Given this list of marker genes PDE6D, INPP5E, ARL13B, here is a description of the gene set: part of: Cargo trafficking to the periciliary membrane Reactome Pathway: ARL13B-mediated ciliary trafficking of INPP5E species: Homo sapiens ARL13B is a ciliary-localized small GTPase with an atypical C-terminus containing a coiled coil domain and a proline rich domain (PRD). Mutations in ARL13B are associated with the development of the ciliopathy Joubert's Syndrome. Studies in C. elegans and vertebrates suggest that ARL13B may play a role in stabilizing the interaction between the IFT A and B complexes and the kinesin-2 motors during anterograde traffic in the cilium. Recent work has shown an additional role for ARL13B in trafficking the inositol polyphosphate-5-phosphatase E (INPP5E) to the cilium through a network that also involves the phosphodiesterase PDE6D and the centriolar protein CEP164. Mutations in INPP5E are also associated with the development of Joubert syndrome and other ciliopathies.